The following is a description of a gene set: from publication Erwin-Cohen RA, Porter AI, Pittman PR, Rossi CA, DaSilva L (PMID 27870591) Genes up-regulated in blood vaccinated vs control in adults (23-48) after exposure to Live attenuated vaccine TC-83, time point 2D Human Gene Set: ERWIN_COHEN_BLOOD_TC_83_AGE_23_48YO_VACCINATED_VS_CONTROL_2DY_UP species: Homo sapiens Venezuelan equine encephalitis virus (VEEV) is an important human and animal alphavirus pathogen transmitted by mosquitoes. The virus is endemic in Central and South America, but has also caused equine outbreaks in southwestern areas of the United States. In an effort to better understand the molecular mechanisms of the development of immunity to this important pathogen, we performed transcriptional analysis from whole, unfractionated human blood of patients who had been immunized with the live-attenuated vaccine strain of VEEV, TC-83. We compared changes in the transcriptome between naive individuals who were mock vaccinated with saline to responses of individuals who received TC-83. Significant transcriptional changes were noted at days 2, 7, and 14 following vaccination. The top canonical pathways revealed at early and intermediate time points (days 2 and 7) included the involvement of the classic interferon response, interferon-response factors, activation of pattern recognition receptors, and engagement of the inflammasome. By day 14, the top canonical pathways included oxidative phosphorylation, the protein ubiquitination pathway, natural killer cell signaling, and B-cell development. Biomarkers were identified that differentiate between vaccinees and control subjects, at early, intermediate, and late stages of the development of immunity as well as markers which were common to all 3 stages following vaccination but distinct from the sham-vaccinated control subjects. The study represents a novel examination of molecular processes that lead to the development of immunity against VEEV in humans and which may be of value as diagnostic targets, to enhance modern vaccine design, or molecular correlates of protection., and this is the list of marker genes: USP18, TOR1B, OAS3, ISG15, IFI16, SRGAP2C, WARS1, ANKRD22, BST2, NCOA7, ZCCHC2, CCL8, TRIM22, MVB12A, EIF2AK2, GBP1, LY6E (lymphocyte antigen 6 family member E), DOCK4, SP140, FBXO6, TFEC, DDX60L, HERC6, STAT1, TNFSF13B, IFI44L (NCBI Gene Id 10964), MT2A, CMTR1, TRIM5 (tripartite motif containing 5), RNF213 (ring finger protein 213), SCO2, SIGLEC1, LGALS9, CCL2, IFI27, PARP9, SHFL, LAMP3, HERC5, RTP4, UBE2L6, MAFB, IFITM1, ETV7, NUB1, CEACAM1, SAMD4A, IRF7, CD274, MS4A4A, IFIT3, PML, SERPING1, IFIT1, TMEM268, LAP3, BLVRA, FRMD3, MOV10, HELZ2, NEXN, GCH1, IFITM2, DDX60, IFI6, SOCS1, OAS2, IFI35 (NCBI Gene Id 3430), IFIH1, PARP12, DRAP1 (NCBI Gene Id 119810), PARP14, OASL, HES4, ZC3HAV1, KIAA0319L (KIAA0319 like), SRGAP2B, TDRD7, CALHM6, RIGI, BATF2, NTNG2, GBP4, GBP5 (guanylate binding protein 5), IL1RN, GALM, EPSTI1, TREX1, RIN2, IFI44, MT1HL1, TNFAIP6 (TNF alpha induced protein 6), ATRIP, MX2, OAS1, SAMD9, MX1, APOBEC3A, STAT2, ISG20, TENT5A, RSAD2, PNPT1, CXCL10, MT1X (NCBI Gene Id 82523), PLSCR1, APOL6, SRGAP2, IFIT5, LIPA, CARINH, TNFSF10, TTC21A, XAF1, ZBP1, SAMD9L, SPATS2L, MT1H, IFIT2